The following is a description of a gene set: Human Gene Set: GSE3982_EOSINOPHIL_VS_CENT_MEMORY_CD4_TCELL_UP Genes up-regulated in comparison of eosinophils versus central memory CD4 T cells. studied in species Homo sapiens from publication Jeffrey KL, Brummer T, Rolph MS, Liu SM, Callejas NA, Grumont RJ, Gillieron C, Mackay F, Grey S, Camps M, Rommel C, Gerondakis SD, Mackay CR (PMID 16474395) In the present study we used Affymetrix oligonucleotide microarrays to produce gene transcription profiles for the major leukocyte types in humans. This comprehensive dataset enabled us to not only establish which genes were expressed in each leukocyte type, but also which genes were expressed in each subset after activation. The used of a comprehensive dataset of gene profiles from all the major human leukocyte subsets enabled a novel and powerful means for identification of genes associated with single leukocyte subsets, or different immune paradigms., and this is the list of marker genes: FRAT1, APLP2, RNF24, XPO6, ZMIZ1, RSRP1, KIT, ERLIN1 (NCBI Gene Id 10613), ASMTL, KLHL4, FTH1, PACSIN2, GSE1, TXNRD1, BCL2A1, FOS, C3AR1, TKT, TYMP, THBS1, FGD6 (FYVE, RhoGEF and PH domain containing 6), TST, ANKRD6, JARID2, ZDHHC7, ADAM8, PTPRE, HSPBAP1, SWAP70, GLRB, TMEM248, PIK3CB, CMTM6, GABARAPL1, ATP6V1B2, PGS1, MEGF9, TRIB1, PTAFR, HK3, ACTN1, ZBTB48, PTPN12, MRFAP1L1, TCF21, ALDOA, CHIA, CENPU, ZNF268, SNN, GPR65, TAF1D, CCNH, SMAD7, H2AC6, MTHFD2, CD244, LEPROT, MAP3K3, EHD1, G0S2, NUP50, ARHGAP26, IL3RA (interleukin 3 receptor subunit alpha), ATP6V0D1, PGD, ACSL4, EVI2B, KAT5, CHI3L1, PROC, PPP1R26, CHSY1, TNFSF13, PLXNC1, MAP3K8, STAP1, HRH4, PDCD4, SLC25A44, RHOQ, PPP4C, GFOD1, UGT2A3, OSER1, ERLIN2, H2BC9, EPN2, PELI2, FNBP1L, WSB1, ERP44, ASAH1, ARHGEF40, NXF2, DSC2, CCL23, MAPKAPK3 (MAPK activated protein kinase 3), ACP3, CHP1, MCMBP, AOAH, PSEN1, CFAP46, RABIF, ALOX15, SERPINA2, DERL1, CKAP4, CPSF6, TUBA1C, KLK3, EYA1, RTF1, AREG, IDH3G, KBTBD11, PIK3R3, CBX2, GSTM1, COQ2, NOTCH2, IPCEF1, ITPRID2, HLA-DRA, KDM6A, NOL10, PTEN (phosphatase and tensin homolog), MBP, ACSL1, WAPL, MAN1A1 (mannosidase alpha class 1A member 1), MMP25, KDM6B, PNPLA6, ORAI2, MGAM, ADIPOR2, PELI1, CTNNAL1, IL18R1, DDR1-DT, STYXL1, SELPLG, CRNKL1, COPB2, NMI, GNAQ, PNRC1, MKRN1, RB1CC1, RALB, MYO5A, PPP1R15A, CLK4, CD55, CEMIP2, FGR, ANPEP, FAM32A, LRRFIP1, LIMK2, RABGEF1, TFEB, SRPK1, CHST15 (carbohydrate sulfotransferase 15), PECAM1, USP22, RREB1, TACC1, FRAT2, GPN3, TMEM9B, BCL6, FCGR2C, PPM1A, ADGRE2, SLA, EBP, NLRX1, RUFY1, TGFBR2, ELOB, PPM1F, USP11, MYH4, SERINC1, SAMD9, SYNJ1, SBNO1, HMG20B, SEC14L1, CREG1, SLC7A11, CYBB, NEU2, TSC22D2, FUCA1, TMEM156, CDA